Given this list of marker genes PAX3, MSRB3, SLC6A13, TUBB6, JPH1, PPFIBP1, QRSL1, LIN28A, NTN1, EIF5B, here is a description of the gene set: Genes predicted to be targets of miRBase v22 microRNA hsa-miR-598-3p in miRDB v6.0 with MirTarget v4 prediction scores > 80 (high confidence targets). from publication Chen Y, Wang X (PMID 31504780) Human Gene Set: MIR598_3P studied in species Homo sapiens